Given this list of marker genes Ube2n, Birc3, Tab2, Optn (optineurin), Map2k7, Tifa, Nfkb2, Ube2d1, Map3k8, Ticam2, Ly96 (NCBI Gene Id 17087), Cd14, Map2k3, Fadd, Ppp2r5d (NCBI Gene Id 21770), Nfkbia, Irf7, Fos, Mapk8, Cul1, S100b, Lrrc14, Vrk3, Nfkb1, Nlrc5, Irak1, Mapk3, Ubb, Mapk14, Nfkbib, Mapk9, Nlrx1, Dusp6, Dusp7, Nkiras1, Tab3, Tlr4, Rps6ka5, Casp8, Ikbkb, Mapk11, Map2k4, Map2k6, Jun, Traf3, Irf3, Rps27a, Hmgb1, Ager (NCBI Gene Id 11596), Ppp2r1b, Ube2v1, Mapk7, Rela (NCBI Gene Id 19697), Tab1, here is a description of the gene set: electronically inferred by orthology from the curated human pathway part of: Toll Like Receptor 4 (TLR4) Cascade Reactome Pathway: MyD88-independent TLR4 cascade species: Mus musculus This event has been computationally inferred from an event that has been demonstrated in another species.<p>The inference is based on the homology mapping from PANTHER. Briefly, reactions for which all involved PhysicalEntities (in input, output and catalyst) have a mapped orthologue/paralogue (for complexes at least 75% of components must have a mapping) are inferred to the other species.